Given this list of marker genes RETREG1, KIF1A (NCBI Gene Id 654843), CHCHD10, YARS1, FLVCR1, SPTLC1, YME1L1, NOTCH2NLC, FXN, SLC12A6, POLG, SACS, MTRFR, EGR2, PMP22, HPDL, RRM2B, MFN2, DNAJC3, TYMP, ATXN1, PTRH2, MPZ, PRX, GDAP1, NGLY1, SCN9A, WNK1, LIG3, here is a description of the gene set: studied in species Homo sapiens Human Gene Set: HP_ABNORMAL_SENSORY_NERVE_CONDUCTION_VELOCITY Abnormal sensory nerve conduction velocity